Given this list of marker genes GDAP1, COLQ (NCBI Gene Id 8292), GNPTAB, LAMB2, SHOX, GNE, AEBP1, OPA3, FLNB, ZMPSTE24, MAP3K7, SALL4, LMNA, PIEZO2, LTBP3, FLNA, TRAPPC2, here is a description of the gene set: Abnormal wrist physiology Human Gene Set: HP_ABNORMAL_WRIST_PHYSIOLOGY species: Homo sapiens Any functional anomaly of the wrist.